The following is a description of a gene set: Mouse Gene Set: MIR_12187_3P studied in species Mus musculus Genes predicted to be targets of miRBase v22 microRNA mmu_miR_12187_3p in miRDB v6.0 with MirTarget v4 prediction scores > 80 (high confidence targets). from publication Chen Y, Wang X (PMID 31504780), and this is the list of marker genes: Dcaf10, Ube2n, Tmem47, Tmed5, Gpr174, Gm6377, Slitrk2, Lrp2, Slc46a3, Rapgef4, Arf6, Cdh9, Dhx15, Pias2, Prl6a1, Naa35, Speer1m, Adam30, Speer1e, Ubr3, Ube2d3, Cyp24a1, Lpp, Ndst3, Ap5m1, Snai2, Gm14308, Fut10, Dnaaf9, Pdgfra, Kbtbd7, Srpk2, Zfc3h1, Dennd1b, Baz1a, Niban1, Fmo9, Fezf1, Rps6kb1, Glyctk, Tfap2b, Cox17, Nuak1, Nr2c2, Vmp1, Phip, Gpr45, Nsd3, Gm14434, Vsx1, Pde4d, Rab6b, 1810037I17Rik, Map2k6, Usp47, Calr3 (NCBI Gene Id 76879), Lap3, Zeb1, Neo1 (NCBI Gene Id 78386), Chchd1, Serpinf2, Cd93, Hoxd12, Ipcef1, Lin7a, Tmem196, Mfhas1, Tet2, Hopx, Mapk6, D2hgdh, Socs6, Cdc73, Irs1, Nkd1, Ano3, Ahcyl1, Itgb1bp1, Naaladl2, Pnkd, Nlrp4b, Rd3, Mospd1, Cntn4, Gria4, Htr2c, Tmem163, Slc28a3, Spn, Mst1r, Nefh, Papss1 (3'-phosphoadenosine 5'-phosphosulfate synthase 1), Armc8, Cbfb, Tmem62 (NCBI Gene Id 96957), Edem3, Taf1, Paqr3, Ncapg (NCBI Gene Id 70636), 5730507C01Rik, Dclk1, Erp44, Vps16, Rtraf, Gpa33, Atl2, Fbln7, Irak4, Heph (hephaestin), Trhr, Cntn1, Ncs1, Macir, Elavl4 (NCBI Gene Id 15572), Lmo4, Zfp936, Apc, Bnip2, Gja1, Dclk3, Ch25h, Abi2, Slfn14, Runx1t1, Rorb, Speer1h, Lrfn5, Caprin1, Atp1b3, C1ql3, Ccdc83, Fgr, Vps41, Tcerg1, Xk, Akap10, Ehf, Zbtb10 (NCBI Gene Id 99802), Vcan, Grb2, Guf1, Lrif1, Mep1a, Zcchc8, Fam81a, Fhip2b, Ifi209, Cybb, Bcl11b, Pclo, Trpc1, Zfp92, Ythdf3, Skil, Ccdc88a, Cnot6l, Speer1a, Ypel5, Sun3, Otud1, Nufip2 (nuclear FMR1 interacting protein 2), Coa7, Samd3, Pdia5, Synm, Adam9, Rims2, Eml4, Bloc1s6, Shox2, Nphp4, Trim45, Agfg1, Calm1, Prrx1, Ushbp1, Il1b, Cep126, Dleu7, Hapln1, Thoc2, Foxd3, Dync2h1, Slc16a9, Fos, Sox21, Brinp3, Arap2, Adhfe1, Shprh, Phldb2, Stxbp1, Gm2026, Snap25, Zbp1, Gm5938, Usp7, Exoc5, B3galt1, Edn1, Npr3, Cdc42se1, Gm715, Blnk, Selenoi, F10, Dach1, Hook3, Dcp1a, Slc1a2, Retn, Zcchc14, Gm4724, Tab3, Yae1d1, Ifi214, Rc3h1, Drosha, Mkks, Cfhr1, Qrfprl, Abhd17b (abhydrolase domain containing 17B), St13, Wapl, Zfp704, Septin12, Eif4enif1, Lrrc2, Ipmk, Slc16a12, Cpeb4, Itga1, Gabrb3, Nfyb, Trim2